The following is a description of a gene set: Human Gene Set: GSE3691_IFN_PRODUCING_KILLER_DC_VS_PLASMACYTOID_DC_SPLEEN_UP To characterize differences between BALB/c splenic CD11cintB220+Gr1+ PDCs (plasmacytoid dendritic cells), CD11cintB220+CD49b+ IKDCs (interferon producing killer-dendritic cells), and CD11chighB220- cDCs (conventional dendritic cells), we performed gene expression profile analysis using Affymetrix chips. We FACS-sorted BALB/c spleen DC subpopulations. Comparison of differentially expressed genes between IKDCs and cDCs vividly revealed selective expression of multiple NK-related genes in IKDCs. These included granzymes A, B, K and M, perforin, Fas ligand, and NK receptors such as NKG2A, NKG2D, Ly49 family genes, NKR-P1, NKG7, NKp46 and Mafa (KLRG1). No NK-related genes were highly expressed in the PDCs. Genes up-regulated in dendiritic cells from speen: interferon producing killer cells versus plasmacytoid. studied in species Homo sapiens from publication Chan CW, Crafton E, Fan HN, Flook J, Yoshimura K, Skarica M, Brockstedt D, Dubensky TW, Stins MF, Lanier LL, Pardoll DM, Housseau F (PMID 16444266), and this is the list of marker genes: TBX1, HSDL2 (hydroxysteroid dehydrogenase like 2), RGS19, SLC43A2, COL5A2, NTN5, KCTD14, SMG1, PIK3C2A, ENDOD1, ULK1, COL6A3, POU6F1, GOLGA5, TBC1D10C, EXT1, ZNF652, RCAN3 (NCBI Gene Id 11123), PRKD2, NRARP, IRF2BP1, MAP4K2, AP1S2, STON1, RINL, KLRC1, SLC35G1, OXA1L, RPS3, ZPBP2, CREBBP, NTAQ1, ZNF579, RAB11FIP2 (NCBI Gene Id 22841), MTSS1, TGFBR2, USP32, N4BP1, IRF8, B3GAT2, MXD4, NFRKB, GM2A, ANKRD12, MYADM, RALGAPA1, CHD3, SNX4, NIN, HBP1, SNORD89, TBL1XR1, RBL1, RAD52, CPD, CACNB3, CAPN1, UNCX, BRF1, NSMCE4A, CTDSPL2, MYL11, CFP, HMGN5, NOXO1, IFT172, SMIM19, EVPL, TAF4B, KCNK6, TTC39B, RNF44, AOPEP, EPC2, ENSG00000286190, HBZ, RAB3GAP1, RMND5A, STK38, STARD10, MTMR1, PIAS1, ACSBG1, CGGBP1, RPL3, PSMG4, DIP2B, PPP1R13B, XRCC4, NEK8, AHRR, ACTR3B, VWA5A, LXN, TXNDC16, SNX17, MMP12, FOXJ2, DGAT2, LITAF, TK2, GPR180, CARD11, NIPAL1, ZZZ3, TEN1, H2AX, SLC44A1, MPP1, CTNNAL1, EPB41L2, YPEL5, NDRG4, TRAK1, TTC9C, RALBP1, CERS5, TBC1D4, FAM78A, PKP3, FEN1, MARK3, PLEKHO1, JUN, NTF4, CD244 (NCBI Gene Id 51744), AP4M1, MAVS (mitochondrial antiviral signaling protein), MANEAL, MMP11, SCN10A, TLE4, ABTB1, EDEM3, ZNF644, ACOX1, KCTD18 (NCBI Gene Id 285170), PPM1L, ARMH3, TAMALIN, SGK1, PLAGL1, KLHL24, CYTH1, SMURF1, IGFBP4, MFSD1, TMED4, MAPK9, ITGB7, PDLIM5, LGALS8, CLK4, MAP7, CFAP300, GALNT10, TSPAN14, ARMCX1, INPP5K, TNFRSF1B, TAPT1, LGALSL, TPD52, DAPK2, RNASE4, CAPN3, AMER1, CHKB, RAB3IP, SNX13, RESP18, ANKRA2, SLC25A26, CERK, SESN1, MEPCE, SLC25A38, TRIM33, NSD3 (nuclear receptor binding SET domain protein 3), SASH3, MAFF, PPP3R2 (NCBI Gene Id 5535), ADAMTS10, COG5, SMC4, ZRSR2, LYSMD3, SS18L1, MAGEE1, WASHC2A, TMEM178A, CNOT11, BCL7B, B4GALT1, DPP7, SMIM14, GOLM1, ACVR1B, FGF13, LRRC28